The following is a description of a gene set: Human Gene Set: GOBP_CARDIAC_SEPTUM_CELL_DIFFERENTIATION species: Homo sapiens The process in which an endocardial cushion cell becomes a cell of a cardiac septum., and this is the list of marker genes: NKX2-5 (NCBI Gene Id 1482), MAML1, KCNJ8, TBX5, BMPR1A